Given this list of marker genes MIR184, DBR1, EBP, BBS2, CRYGB, EPHA2, CRYAB, PEX5, PITX3, TAOK1, APC, VIM, LZTR1, HS2ST1, COL4A3, ZBTB20, ITM2B, HSF4, here is a description of the gene set: Polar cataract A type of Congenital cataract in which the opacities occupy the subcapsular cortex at the anterior or posterior pole of the lens. species: Homo sapiens Human Gene Set: HP_POLAR_CATARACT